Given this list of marker genes Kcnn4 (NCBI Gene Id 16534), Cd2 (CD2 antigen), Ugp2 (UDP-glucose pyrophosphorylase 2), Mkrn1, Use1, Vim (vimentin), Marcks, Bach2, Eif3b, Guk1, Rac2, Jak1, Rpl18, Snrpb, Eif3l, Tpr, Pstpip2, Gmps, Mtmr9, Atp5mc2, Gsta4, Ruvbl1, Ddx54 (NCBI Gene Id 71990), Eif3h, Lrpap1, Qars1, Samsn1, Cdc37, Dctn3, Specc1, Ftl1, Hcls1, Fis1, Pnp, Itm2b, Cyba, Psmb8 (proteasome (prosome, macropain) subunit, beta type 8 (large multifunctional peptidase 7)), Oaz1, Timm13, Stambpl1, Ppm1m, Rbm33, Myl6, Cd24a, Xpo4, Ndufa9, Rpl32, Cntrl, Ik, Mdh1, Cast, Rps9, Scart1, Uck2, Bmyc, Strn3, Mtf2, Amd1 (S-adenosylmethionine decarboxylase 1), Akr1b1, Gdi2, Eno1, Jak2, Bcl2l11, Gpr83, Prps1, Cct2, Nrgn, Mrpl46, Hnrnpf, Chchd2, Rps7, Ech1, Nfkb2, Mcm6, Eif3m, Ppdpf, Cd47, Nkg7, Ccdc22, Ptp4a2, Pdrg1, Lig1, Klhdc2, Lgals1, Smo, Sar1a, Supt4a, Unc119b, Rap1gds1, Trbv14, Lonp1, Stat1, Strap, Anxa6, Rtcb, Reep5, Fam50a, Adgrg3, Atp5f1b, Mthfd1, Alg5, Rpl10, here is a description of the gene set: Mouse Gene Set: GAVIN_FOXP3_TARGETS_CLUSTER_T7 from publication Gavin MA, Rasmussen JP, Fontenot JD, Vasta V, Manganiello VC, Beavo JA, Rudensky AY (PMID 17220874) Cluster T7 of genes with similar expression profiles in thymic T lymphocytes after FOXP3 loss of function (LOF). studied in species Mus musculus Regulatory CD4+ T cells (Tr cells), the development of which is critically dependent on X-linked transcription factor Foxp3 (forkhead box P3), prevent self-destructive immune responses. Despite its important role, molecular and functional features conferred by Foxp3 to Tr precursor cells remain unknown. It has been suggested that Foxp3 expression is required for both survival of Tr precursors as well as their inability to produce interleukin (IL)-2 and independently proliferate after T-cell-receptor engagement, raising the possibility that such 'anergy' and Tr suppressive capacity are intimately linked. Here we show, by dissociating Foxp3-dependent features from those induced by the signals preceding and promoting its expression in mice, that the latter signals include several functional and transcriptional hallmarks of Tr cells. Although its function is required for Tr cell suppressor activity, Foxp3 to a large extent amplifies and fixes pre-established molecular features of Tr cells, including anergy and dependence on paracrine IL-2. Furthermore, Foxp3 solidifies Tr cell lineage stability through modification of cell surface and signalling molecules, resulting in adaptation to the signals required to induce and maintain Tr cells. This adaptation includes Foxp3-dependent repression of cyclic nucleotide phosphodiesterase 3B, affecting genes responsible for Tr cell homeostasis.